Given this list of marker genes Notch1, Eng, Heyl, Tgfb3, Snai1, Rbpj, Fgf8, Msx2, Tgfb2, Tgfb1, Hey1 (NCBI Gene Id 99610), Tgfbr1, Msx1, Smad4, Tmem100, Bmp4, Tgfbr2, Snai2 (NCBI Gene Id 20583), here is a description of the gene set: species: Mus musculus A transition where a cardiac epithelial cell loses apical/basolateral polarity, severs intercellular adhesive junctions, degrades basement membrane components and becomes a migratory mesenchymal cell that will contribute to the formation of the endocardial cushion. Mouse Gene Set: GOBP_EPITHELIAL_TO_MESENCHYMAL_TRANSITION_INVOLVED_IN_ENDOCARDIAL_CUSHION_FORMATION